Given this list of marker genes RBM38, AKAP12, NRAS, NCAM1, HTRA1, ANKRD1, RBPMS, FBLN2, CDKN2A, ZFTRAF1, PKIA, LIMK1, RPS6KA2, PLEKHO1, here is a description of the gene set: Human Gene Set: CASTELLANO_NRAS_TARGETS_DN We characterized differential gene expression profiles of fibroblast cell lines harboring single or double-homozygous null mutations in H-ras and N-ras. Whereas the expression level of the individual H-, N- and K-ras genes appeared unaffected by the presence or absence of the other ras loci, significant differences were observed between the expression profiles of cells missing N-ras and/or H-ras. Absence of N-ras produced much stronger effects than absence of H-ras over the profile of the cellular transcriptome. N-ras(-/-) and H-ras(-/-) fibroblasts displayed rather antagonistic expression profiles and the transcriptome of H-ras(-/-) cells was significantly closer to that of wild-type fibroblasts than to that of N-ras(-/-) cells. Classifying all differentially expressed genes into functional categories suggested specific roles for H-Ras and N-Ras. It was particularly striking in N-ras(-/-) cells the upregulation of a remarkable number of immunity-related genes, as well as of several loci involved in apoptosis. Reverse-phase protein array assays demonstrated in the same N-ras(-/-) cells the overexpression and nuclear migration of tyrosine phosphorylated signal transducer and activator of transcription 1 (Stat1) which was concomitant with transcriptional activation mediated by interferon-stimulated response elements. Significantly enhanced numbers of apoptotic cells were also detected in cultures of N-ras(-/-) cells. Our data support the notion that different Ras isoforms play functionally distinct cellular roles and indicate that N-Ras is significantly involved in immune modulation/host defense and apoptotic responses. Genes down-regulated in MEF cells (embryonic fibroblast) isolated from NRAS knockout mice. studied in species Mus musculus from publication Castellano E, De Las Rivas J, Guerrero C, Santos E (PMID 16909116)